The following is a description of a gene set: Any process that modulates the frequency, rate, or extent of leukocyte degranulation. studied in species Homo sapiens Human Gene Set: GOBP_REGULATION_OF_LEUKOCYTE_DEGRANULATION, and this is the list of marker genes: UNC13D, GATA2, CD300A, CD84, LAMP1, FCER1G, SPHK2, HLA-F, BCR, GAB2, PRAM1, SPI1, PLA2G3, ITGAM, FERRY3, CD177, CD160, FES, PDPK1, SNX4, LYN, GATA1, CCR2, ITGB2, CEACAM1, ADGRE2, FOXF1, IL4R, KLRC2, IL13, SYK, STXBP2, VAMP8, ADORA2B, F2RL1, NCKAP1L, IL13RA2, AP1G1, FGR, STXBP1, VAMP7, STX4, FCGR2B, LGALS9, RABGEF1, RAC2